The following is a description of a gene set: species: Homo sapiens The directed movement of the nucleus to a specific location within a cell. Human Gene Set: GOBP_NUCLEAR_MIGRATION, and this is the list of marker genes: PAFAH1B1, TRIM58, SYNE2, TMEM201, SLIT1, SYNE3, MYH10, CLMN, NUDC, LMNA, PCM1, CEP120, DOCK7, NTN1, DYNC1H1, LMNB1, LMNB2, SUN2, NHERF1, CDC42, TACC1, TACC2, HOOK3, FBXW11, FHOD1, TACC3, DCTN1, SUN1